The following is a description of a gene set: Mouse Gene Set: MIR_3473F from publication Chen Y, Wang X (PMID 31504780) Genes predicted to be targets of miRBase v22 microRNA mmu_miR_3473f in miRDB v6.0 with MirTarget v4 prediction scores > 80 (high confidence targets). studied in species Mus musculus, and this is the list of marker genes: Plppr5, Mblac2, Sntg1, Coq10b, 9330159F19Rik, Wac, Pomgnt2, Gpr158, Eif4ebp2, Tpm4, Adamts14, Mecp2, Ankib1 (ankyrin repeat and IBR domain containing 1), Arap2, St3gal4, Asah2, Zfp280b, Il1rl1, Nr1d1, Sorbs1, Ino80d, Plxna3, Enah, Gpr155, Nkapd1, Lrrk2, Adamts3, Prune2, Erich3, Sox6, Prr18, Pwwp3b, Dio2, Srgap2, Itga3, Amer1, Zbtb43, Cd55, 2310002L09Rik, Fdx1, Cep290, Zbtb10, Rab43, Snap91, Bub1, Cldn23, Nufip2, Arl5b, Casr, Ahdc1, Csgalnact2, Ric8b, Tasl, Il17a, Tbc1d13, Ehf, Akap10, Lrch4, Slc23a2, Enc1, Taok1, Dazl, Wipf1, Wnt9a, Ints2, Fmn2, Atp2b4, Rufy2, Efna5, Taf4, Csnk1g3, Stard13, Ate1, Kif5b, Cdca4, Jund, Il1b, Arhgap17 (Rho GTPase activating protein 17), Osbpl3, Fignl2, Timm17a, Plxna1, Senp1, Ski, St3gal5, Ypel5, Pmp22, Lif, Rspo2, Rbm24, Midn, Tgfa, Nap1l1, Fgd4, Retreg1, Aff4, Cntn1, Zfp583, Lats1, A830018L16Rik, Ccndbp1, Nav1, Acvr2a, Plppr4, Wls, Cemip, Zic3, Elavl3, Peli1, Ankrd39, 2510009E07Rik, Cxcl2, Prorsd1, Fhl2, Adamts20, Btbd6 (NCBI Gene Id 399566), Phf8l, Nog, Frk, Cyth3, Cdh11, Fmnl2, Kdm7a (lysine (K)-specific demethylase 7A), Yap1, Pdgfc, Runx2, Ppp1r15b, Dnajc6, Sgk3, Birc6, Csrnp2, Rab3a, Ihh, Cd274, Il3, Zbtb7c, Clec4e, Foxd1, Spns2, Eogt, Hic2 (NCBI Gene Id 58180), Wapl, Dcaf15, Slc5a12, Grm1, P4ha1, Stim2, Mprip, Fzd2, Pkp2, Aida, Srpk2, 4930447C04Rik, Gucy1a2, Gabrp, Aldh1a2, Cd40lg, Capn10, Mllt3, Ell2, Pdzrn4, Pcdh7, Slc39a8, Slc12a4, Mapre3, Rcan2, Igf2r, Evi5, Satb2, Fndc3a, Tex261, Nr4a2, Kifc3, Tbc1d15, Ankrd1, Ccl20, Ppt1, Zfp804a, Raph1 (NCBI Gene Id 77300), Gria2, Tmem120b, Lrp2, Tma7, Adcyap1, Pknox1, Iqgap2, Ppif, Ifng, Atad2, Ythdf3, Sh3pxd2a, Atxn7l3, Slc39a2, Myrf, Shisa3, Pbsn, Zc4h2, Negr1, Ift122, Bdnf, Jmjd6, Il12a, Il2, Larp4, Pomgnt1